Given this list of marker genes ELAVL4 (ELAV like RNA binding protein 4), KLHDC8A, CXADR, GPC2, SYT1, CRMP1, NREP, ARL4D, DLX5, PAK3, TERF2IP, KIF5C, SOX4 (NCBI Gene Id 6659), SCG2, STMN1, DDAH2, TCEAL7, JPT1, MLLT11, RTN1, SOX11, BASP1, TMEM161B-DT, SCG3, DCX, RND3, PKIA, GNG3 (NCBI Gene Id 2785), IGFBPL1, BEX2, NNAT, CD24, TAGLN3, TUBB2A, STMN2, TUBB3, MAP1B, MIAT, GAP43, DLX6-AS1, STMN4, NSG2, RBFOX2, SNAP25, NSG1, RBP1, UCHL1, MEG3, FNBP1L, ENO2, here is a description of the gene set: species: Homo sapiens In this study, an extensive analysis was conducted to define meta-programs (MPs) capturing intra-tumor heterogeneity across a spectrum of tumor types. The approach utilized non-negative matrix factorization (NMF) to analyze each cell type separately within individual tumor samples. This involved the analysis of malignant cells, macrophages, fibroblasts, endothelial cells, epithelial cells, T-cells, and B-cells. NMF was executed with varying parameter values (K=4, 5, 6, 7, 8, 9), thereby generating 39 programs for each cell type per sample. Each NMF program was summarized by the top genes based on NMF coefficients.\nRobust MPs were then delineated for each cell type using a set of stringent criteria, including recurrence within the same tumor, similarity to programs in other tumors, and non-redundancy within a tumor. Subsequently, these robust NMF programs were clustered (per cell type) based on Jaccard similarity, leading to the identification of MPs associated with each cell type.\nTo enhance the quality of the MPs, a refinement steps were undertaken, involving the removal of MPs suspected of reflecting low-quality data (with an overrepresentation of ribosomal proteins or mitochondrial-encoded genes), single-study inclusion, or similarity to miss-annotated cell types. Genes upregulated in subsets of cells of a given type within various tumors from publication Gavish A, Tyler M, Greenwald AC, Hoefflin R, Simkin D, Tschernichovsky R, Galili Darnell N, Somech E, Barbolin C, Antman T, Kovarsky D, Barrett T, Gonzalez Castro LN, Halder D, Chanoch-Myers R, Laffy J, Mints M, Wider A, Tal R, Spitzer A, Hara T, Raitses-Gurevich M, Stossel C, Golan T, Tirosh A, Suvà ML, Puram SV, Tirosh I (PMID 37258682) Human Gene Set: GAVISH_3CA_MALIGNANT_METAPROGRAM_26_NPC_GLIOMA